The following is a description of a gene set: Human Gene Set: GOBP_REGULATION_OF_MEMBRANE_REPOLARIZATION_DURING_VENTRICULAR_CARDIAC_MUSCLE_CELL_ACTION_POTENTIAL species: Homo sapiens Any process that modulates the frequency, rate or extent of membrane repolarization during ventricular cardiac muscle cell action potential., and this is the list of marker genes: MIR1-1, NOS1, MIR133A1, KCNE3, CASQ2, NOS1AP, RNF207